Given this list of marker genes Wnt5a, Vcam1, Pde1c, F2r, Minpp1, Abcc1, Slc34a3, Itpr2, Glul, Hcrtr1, Rptor, Slc12a3, Abcc2, Mir369, Xk, Tns2, Avp, Slc30a1, Rmdn3, Htr2a, Dgat2, Ccdc115, Itpr3, Slc41a1, Mir192 (microRNA 192), Hamp, Rtn4, Ppp3cb, Tmem94, Ccr2, Gaa, Slc4a3, Jsrp1, Ube2k, Lamp2, Lyn, Snca, Ccdc186, Itpr1, Gpr12, Bsnd, Ccdc51 (coiled-coil domain containing 51), Mapk1, Fshr, Atp6v0d1, Pik3ca, Psen2, Pnpla2, Add1, Rab38, Gcg (glucagon), Hk2, Lgsn, Maip1, Pdx1, Crocc, Mcur1, Calb1, Lcn2, Ciao3, Slc40a1, Npy, Ncoa4, Drd1, Ide, Selenot, Meltf, Ube2srt, Atp6v0e2, Tmprss6, Ptk2, Txn2, Ccr1, Casq1, Slc30a8, Mir379, Slc30a9, Slc31a1, Cd40, Slc12a7, Drd2, Hexb, Mir532, Lrrc8a, Jph3, Tcirg1, Chd7, Htt, Alpl, Sv2b, Atp6v0a1, Clcc1, Cln3, Prdx4, Calcb, Ibtk, Cp, Tmc8, Apoe, Wnk1, Slc39a10, Ednra, Foxk1, Twnk, Slc9a9, Atp1a2 (ATPase, Na+/K+ transporting, alpha 2 polypeptide), Atp13a4, Chga, Sgk1, Tmem178, Pth, Oprk1, Aqp2, Slc9b1, Drd3, Atp6v0a2, Mir410, Snapin, Cav2, Nucks1, Hfe, Tpp2, Slc9a1, Srf, Klf7, Slc25a27, Akap6 (NCBI Gene Id 238161), Stx4a, Mapk3, Socs6, Adra2a, Steap2, Grin1, C1qtnf3, Itgav, Abcb6, Tfr2, Vdr, Steap4, Atp2b1, Mettl21c, Acacb, Slc39a12, Commd1, Fasl, Calm1, Slc34a2, Picalm, Fkbp1b, Hmox2, Slc24a3, Ccl19-ps6, Ubash3b, Ccl5, Trpc7, Klf15, Cacna1f, Cnr1, Bola2 (NCBI Gene Id 66162), Ftmt, Stim1, Gdf2, Abcb7, Prdx3, Rhag, Trdn, Thy1, Letm1, Egln1, Htr1b, Mtln, Clcnkb, Il1a, Shank3, Trpa1, Scnn1a (NCBI Gene Id 20276), Clstn1, Tnni3, Atp2c2, Slc12a2, Myt1, Ero1a, Eif3e, Gstm7 (NCBI Gene Id 99761), Tbxas1, Atp6v1e1, Atp13a1, Ccl21a, Ccl19-ps4, Slc45a2, Herpud1, Ptprc, Kif5b, Slc35g1, Trpm8, Cxcr3, Smad1, Cnnm4, Afg3l2 (AFG3-like AAA ATPase 2), Mt2, Elp6, Birc5, Rab7, Gp9, Tmem38a, Coro1a, Csrp3, Smad2, Bag3, Htr2c, Plce1, Tmc6, Mup1, Lrrk2, Cyba, Chp1, Grina, Clcn3, P2ry2 (purinergic receptor P2Y, G-protein coupled 2), Sctr, Creg1, Fto, Cdh5, Kcnma1, Atp2a2, Slc12a5, Ccl19, Serpinf1, Egln2 (NCBI Gene Id 97399), Rnf135, Mup3, Pck1, Tmem106b, Spns1, Atp6v1h, Slc39a8, Ank (NCBI Gene Id 52488), Atp6v1g2, Ntsr1, Car7, Gimap6, Cox19, Tsc22d4, Calm3, Hif1a, App, Ccl21b, Slc39a9, Trpm4, Ttpa, C7, Micu2, Bnip3, Ptpmt1, Slc30a2, Mir27a, Mexis, Crh, Plcl1, Ncs1, Aim2, Trem2, Erc2, Tm9sf4 (NCBI Gene Id 99237), Edn3, Scnn1g, Hmgcr, Abcc8, Ppp3ca, S100b, Cyb561a3, Slc9b2, Foxa3, Disc1, Slc2a2, Sidt2, Atp6v1b1, Tex101, Tasl, Atp6v1c1 (NCBI Gene Id 98003), Slc24a5, Mecr, Mir200a, Plcl2, Smad3, Atp6ap1l, Cyb561, Tjp1, Aqp1, Fkbp1a, Gpr39, Pik3r1, Plcg1, Lhcgr, Rnasek, Pde4c, Rab11b (RAB11B, member RAS oncogene family), Cnga1, Cst5, Ucp2, Nherf1, Grm1, Neo1, Ngf, Sin3a, Fate1, Osbpl2, Ngfr, Plaa, Slc26a3, Smarca4, Atp6v1f, Snx10, Slamf8, Atp1a3, Capn3, Ano6, Erc1, Epha5, Gp5, Slc4a2, Slc6a12, Gpx1, Gpr68, Brsk2, Slc29a1, Atp1a4, Taok1, Acvr2b, Avpr1a, Gckr, Ano1, P2ry4, Pdzd8, Ptpn6, Slc24a4, Trf, Atox1, Cftr, Ambra1, Anxa6, Prdx6, Atp6v1g1, Bok, Bdkrb1, P2rx2, Rbm4, Lrp5, Atp7b, Mfn2, Bax, Cdk16, Trpm2, Letmd1, Mt1, Grid2ip (glutamate receptor, ionotropic, delta 2 (Grid2) interacting protein 1), Dmtn, Pygm, Plcb1, Hcrtr2, Hmox1, Dhrs7c, Atp6ap2, Gpld1, Psen1, Ace, Rab34, Cacna1s, Rap1gds1, Apc, Plch1, Gsr, Foxa2, Prdx1, Slc4a8, Myh7b, Txnrd1, Fitm2, Hrc (NCBI Gene Id 15464), Chmp2b, Icam1, Tyro3, Atp4b, Casr, Il2rg, Edn1, Glp1r, Slco2b1, Rac1, Efna5, Erfe, Ins1, Slc9a6, Mir130a, Dmpk, Pml, Prdx6b, Lrrc8d, Krit1, Rab11fip5, Flna, Atp2b3, Calb2 (NCBI Gene Id 12308), Cav1, Smad4, Lrp1, Efhc1, Trpv5, Tcf7l2, Ldah, Prkca, B2m, Gclm, Asl (argininosuccinate lyase), Large1, Slc4a5, Ctrc, Nol3, Asph, F2 (NCBI Gene Id 14061), Slc8b1, Neurod1, Slc12a6, Nr1h4, Lrrc8e, Calm2, Smad5, Hk1, Trim6, Pkd2, Fggy, Hjv, Prdx2, Atp6v1b2 (NCBI Gene Id 97492), Fcrl5 (NCBI Gene Id 329693), Mt4, Htr2b, Nucb2, Scara5 (NCBI Gene Id 74378), Plg, Sv2a, Ptprn2, Itgb3, Ryr1, Irs2, Kel, Smarcb1, Slc9a5, Casq2, Il13, Ppard, Mtm1, P2ry1, Aplp2, Slc8a1, Xbp1, Slc11a1, Lin28a, Ankrd9, Cx3cl1, Ormdl2, Slc39a14, Osbp, Wnt7b, Gpr27, Abcc6, Gpr3, Ero1b, Fth1, Tmbim6, Tmem199, Slc66a1, Sri, Ghrl, Mup11, Il6, Alas2, Tmem175, Slc39a4, Rab39, Atf4, Mir320, Grik2, Cxcl11, Kcnn4, Slc24a1, P2rx7, Fthl17e, Cdh23, Slc4a4, Rack1, Pde8b, Thada, Gls, Adcy5, Raf1, Pik3cb, Plcg2, Slc17a7, Foxk2, Piwil4, Atp1b3, Gp1bb, Bmyc, Steap3, Plcb2, Abca2 (NCBI Gene Id 98943), Scn7a, Gnb3, Trpv4, Slc4a10, Prkaa1 (protein kinase, AMP-activated, alpha 1 catalytic subunit), Slc11a2 (NCBI Gene Id 18174), Cyp7a1, Slc8a3, Glrx3, Atp6v1g3, Pde3b, Micu1, Xpr1, Cacna1a, Atp6v1d, Hkdc1, Atp2b4, Slc39a6, P2rx1, Mpc2, Zng1, Cfl2, Prkn, Atp1a1, Rgn, Sybu, Bcl2, Slc30a10, Atp2a1, Tmem203, Npsr1, Sppl2c, Clic4, Cox11 (NCBI Gene Id 69802), Fxn, Camk2d, Bap1, Atp1b1, Hap1, Cisd1, Atp13a3, Txnrd3, Kcnh1, Ryr2, Ube2c, Slc12a1, Vapb, Ywhae, Tmem165, Fgf23, Pik3r2, Ccl19-ps3, Hps1, Il7r, Atp6v0d2, Fcor, 1600014C10Rik, Tmprss3, Gck, Tra2b, Slc26a6, Mcoln1, Cacnb4, Kctd17, Ncoa6, Pax6, Slc4a1, Bak1, Slc1a1, Atp1b2, Sirt1, Cdk5 (cyclin dependent kinase 5), Dctn1, Eny2, Sco1, Mstn, Endog, Slc31a2, Tesc, Crhr2, Gcm2, Drd4, Sod1, Ap3b1, Fmr1, F2rl3, Igf1r, Lck, Atp13a5 (NCBI Gene Id 268878), Scnn1b, Slc9a3, Alms1, Calca, Wdtc1, Trp53, Fbxw7, Ank2, Slc9a8, Cacnb2, Atg5, Agt, Ppt1, Ptprn, Enpp1, Myo5a, Tmem64, Cd19, Cacna1e, Ccdc47 (NCBI Gene Id 97906), Mup5, Camk2n1, Mcub, Map1a, Cltrn, Nubp1, Gprc5b, Ube3a, Git1, Lamp1, Xcr1, Diaph1, Fxyd2, Nadk (NAD kinase), Cherp, Vps54, Ifnb1, Cxcl10, Th, Trpc2, Cln6, Col1a1, Vsnl1, Ogt, Ireb2, Pdpk1, Cxcl9, Stc2, Tfrc, Pln, Marcksl1, Rhot2, Inpp4b, Immt, Pacs2, Clec4b1, Agtr2, Slc12a9, Mon1a, Hcfc1, Pth1r, Slc9a2, Npm1, Foxo3, Mup2, Rab11fip2, Ttc7, Ccl8, Ccr5, Stim2, Ang2, Atp6v0c, Kcnb1, Ager (advanced glycosylation end product-specific receptor), Cav3, Fundc2b, Pim3, Ube2s, Spp1, Prnp, Slc38a3, Cacna1c, Txnrd2, Slc24a2, Mt3, Car2, Pde4d, Mup4, Kcnj11, Plcb4, Oca2, Trpc6, Rhcg, Ccl19-ps5, Aqp11, Igf1, Jph2, Selenos, Gas6, Arrb1, Kctd7, Mcu, Lacc1, Hpx, Tgm2, Plcd1 (NCBI Gene Id 97538, phospholipase C, delta 1), Aqp4, Cartpt, Adcy8, Gpr89, Tunar, Dmd, Hamp2, Usf1, Tmem38b, Ptk2b, Nnt, Fzd9, Slc34a1, Slc7a11, Ccl21f, Ddit3, Prkaa2, Prkd1, Plcb3, Ccl2, Wnk4, Fxyd1, Sct, Trpc4, Tpcn2, Slc30a5, Ormdl3, Oxct1, Nppc, Ern1, Apex1, Tmtc4, Jagn1, Slc9a7, Oxsr1, Atp2a3, Atp2b2, Haao, Ghitm, Serpinb1a, Iscu, Hk3, Unc13b, Atp13a2, Bad, Abl1, Stoml2, Ccdc22, Ms4a2, Micu3, Nfe2l2, Mir337, Zbed6, Dmxl2, Dbi, Tgfb2, Chrna1, Edn2, Ftl1 (ferritin light polypeptide 1), Baiap3, Aacs, Gjb6, Slc39a13, Atp6v1a, Atp4a, E2f4, Atp2c1, Cemip, Lepr, Hmgn3, Cul5, Xcl1, Apoc3, Trpm5, Ifng, Pih1d1, Kcne3, Slc9a4, Aldoa, Cacna1d, Usf2, Chd6, Gp1ba, Rhot1, Arf1, Prkg2, Fundc2 (NCBI Gene Id 67391), Slc4a7, Txn1, Selenon, Mafg, Rfx6, Grk2, Wfs1 (wolframin ER transmembrane glycoprotein), Prkaca, Hnf1a, Adora1, Hvcn1, Plch2, Nptx1, Tbc1d1, Npy1r, Myh9, Atp12a, Stxbp3, Tgfb1, Aco1, Hephl1, Ckb, Atp7a, Adnp, Sypl2, Cngb1, Slc12a4, Mlxipl, Stk39, Synpo (synaptopodin), Grn (NCBI Gene Id 14824), Gsto1, Abca12, Stc1, Slc25a23, Trpc1, Tiam1, Pck2, Slc12a8, Slc1a3, Slc37a4, Prkcb, Ryr3, Grm2, Slc30a7, Anxa7, Lcn6, C1qtnf12, Ccl19-ps1, Pkhd1, Slc4a11, Cln5, Atp5f1b, Slc10a7, Slc8a2, Trim32 (NCBI Gene Id 69807), Tmco1, Atp6v0a4, Trpc3, Map4k4, Ndufaf2, Bloc1s6, Vps33a, Selenok, Prdx5, Nr3c2, Rab20, Trpm7, Dmxl1, Kat5 (NCBI Gene Id 81601), Gclc, Trpc5, Pla2g6, Abcg1, Fbxl5, Frrs1, Zbtb20, Slc2a10 (NCBI Gene Id 53907), Ormdl1, Lime1, Ranbp2, Wnk3, Gprc6a, Smdt1, Frey1, Sod2, Atg7, Slc39a7, Ccl3, Abcb8, P2ry6, Cpb2, Clns1a, Kcnq1, Umod, Lox, Sox4, Rimbp2, Ccl21d, Sco2, Nell2, Ndfip1, Nqo1, Fgf2, Pax2, Nfe2l1, Stxbp4, Star, Mink1, Grin2b, Nr1d1, Atp6ap1, Bmp6, Nptn, Prkce, Cybrd1, Myc, Ccl21e, Tmem9, Tspoap1 (NCBI Gene Id 207777), Slc4a9, C2cd2l, Nox4, Dynll1, Slc9c1, Pfkm, Slc39a5, Prnd (NCBI Gene Id 98975), Fbxo4, Aplnr, Ccr1l1, Gper1, here is a description of the gene set: Any process involved in the maintenance of an internal steady state at the level of the cell. Mouse Gene Set: GOBP_CELLULAR_HOMEOSTASIS studied in species Mus musculus